Given this list of marker genes ZNF366, CNOT1, CNOT2 (NCBI Gene Id 51498), CNOT9, BRCA1, KANK2, CYP7B1, CDK12, PHB2, LBH, VPS11, ISL1, TP63, VPS18 (VPS18 core subunit of CORVET and HOPS complexes), STRN3, here is a description of the gene set: species: Homo sapiens Any process that stops, prevents, or reduces the frequency, rate or extent of the activity of an intracellular estrogen receptor signaling pathway. Human Gene Set: GOBP_NEGATIVE_REGULATION_OF_INTRACELLULAR_ESTROGEN_RECEPTOR_SIGNALING_PATHWAY